Given this list of marker genes RAB11FIP4, ZFC3H1, TMEM54, ZBTB7B, SERPINB7, LCE1B, SPIN3, BIRC2, PIK3R2 (NCBI Gene Id 5296), INAVA, CDK18, ZNRF2, MLLT6, IL17RD (NCBI Gene Id 54756), SOX13, DIRAS1, PDE1B, ARRB2, PLXNA4, NFIX, SLC9A8, CALR, IHH, XYLB, UBTF, PLVAP, GRHL2, CYP2B6, SPRR1B, SLC25A42, TBC1D10B, PCDHB11, FAM234A, AFAP1, LSAMP, ATAD3C, DYRK1A, ST13, SF3A2, UBE2QL1, NHERF2, PPT2, PLA2G2D, TCF7, PTHLH, FOXC1, COL9A2, ANKRD26, ANKRD52, LIX1L, NFIC, STAC2, PHLPP1, CADM4, TNFSF12, MECP2, BSN, TMEM222, ZNF691, POU2F2, NFASC, JPH4, PRR5L, PKNOX2, METTL9, ATP9A, CASTOR2, KMT2D, MPZ, NOVA2, FBXO43, THRSP, DEF8, MIEN1, MNT, RSU1 (Ras suppressor protein 1), MAP1A, ACSL5, PPP2R2D, LRRC28, WNK4, WNT3, FOXP4, SNX29, MTSS2, LRRC59, ELAVL3, ADORA3, ELK1, SLC28A1, HMGA1, MFRP (NCBI Gene Id 83552), NR1D1, EN1, CTNND1, FOXE1, LRATD2, BSDC1, MED19, VPS37D, SCGB2B2, ITGA3, EPB41L1, C6orf141, CNIH2 (NCBI Gene Id 254263), SLC7A8, SYNGAP1, PRC1, DDX31, ACTB, DUSP10, PPP2R5E, CDR2L, RERG, TCP11L1, PSMF1, DIRAS2, TLE3, MYL12A, CAMK1D (NCBI Gene Id 57118), BMP1, SHISAL1, FAM131B, PRR23A, CLSTN1, NLGN2 (NCBI Gene Id 57555), PRR12, TMEM198, PAX5, MAT1A, SLC8A2, FAM174B, LRP8, PDLIM4, COTL1, DMWD, CCL22, CXADR, PACS1, CELF3, PSME3, TFAP2B, CNST, GPRC5A, TREML1, SZRD1, PVALB (parvalbumin), NAPA, IKZF4, APBA1, DYSF, DVL3, FADS2, CTDSP1, AP2M1, TRAM2, TMEM151A, C19orf12, TMEM63B, MINK1 (misshapen like kinase 1), FGF1, STIM1, KALRN, CES4A, KCNC3, PHC2, GATAD2B, RBM23, RBMS3, SMARCC2, PPP1R9B, GAS7, CCDC102B, SH3TC2, H1-10, PANX2, SHANK2, SNPH, UBAP2L, CCDC97, DPYSL5, PRKACA, MAP7D1, ZDHHC15, RANBP10, MEX3A, NAT16, CHRNA4, IGSF11, CPS1, SLC6A17 (NCBI Gene Id 388662), C9orf57, HEYL, SRF, PPP2R1A, CAMKK2, FKBP8, APLNR, CNTNAP1, WIZ, GTPBP2 (GTP binding protein 2), here is a description of the gene set: Human Gene Set: MIR5698 Genes predicted to be targets of miRBase v22 microRNA hsa-miR-5698 in miRDB v6.0 with MirTarget v4 prediction scores > 80 (high confidence targets). studied in species Homo sapiens from publication Chen Y, Wang X (PMID 31504780)